The following is a description of a gene set: Any process that modulates the frequency, rate or extent of neutrophil migration. studied in species Mus musculus Mouse Gene Set: GOBP_REGULATION_OF_NEUTROPHIL_MIGRATION, and this is the list of marker genes: Ednra, Fut7, Jam3 (NCBI Gene Id 97553), Ccl19-ps1, Rac2, Tnfaip6, Il1b, Dysf, Fut4, Pawr, Ccl21f, Slit2, Ccl21b, Thbs4 (thrombospondin 4), Cd99l2, Lbp, Rtn4, Mospd2, Nod2, Myd88, Ccl19-ps6, Perp, Adam8, Sell, Nckap1l, Ccl19-ps4, Cxcr2, Ccl21a, Xcl1, Ccl19, C1qbp, Ripor2, Selenok, Ccl21e, C5ar2, Mpp1 (NCBI Gene Id 17524), Dpp4, Dapk2 (death-associated protein kinase 2), Ccr7, Dnm1l, Rac3, Rac1, Il23a, Il1r1, Tirap, C3ar1, Ptger4, Cd74, Mdk, C5ar1, Edn1, Tlr2, Ccl19-ps3, Slamf8, Camk1d, Myo1f, Ptger3, Ccl21d, Ccl19-ps5, Il1a, Bst1, Mcu